The following is a description of a gene set: studied in species Mus musculus Mouse Gene Set: GOBP_BRANCHING_INVOLVED_IN_SALIVARY_GLAND_MORPHOGENESIS The process in which the branching structure of the salivary gland is generated and organized., and this is the list of marker genes: Hgf, Tnf, Il6, Lama1, Fgf7, Fgfr2, Esrp1, Fgfr1, Met, Dag1, Snai2, Fgf10, Cdh1, Tgm2, Plxnd1, Lama5, Pdgfb, Sema3a, Bmp7, Btbd7, Fgf8, Nrp1, Ntn4, Esrp2, Sema3c, Plxna1 (NCBI Gene Id 70046), Pdgfa, Shh